The following is a description of a gene set: Human Gene Set: MIR5088_5P Genes predicted to be targets of miRBase v22 microRNA hsa-miR-5088-5p in miRDB v6.0 with MirTarget v4 prediction scores > 80 (high confidence targets). species: Homo sapiens from publication Chen Y, Wang X (PMID 31504780), and this is the list of marker genes: KDM2A, TMEM47, XRCC6, HIC2, GALNT2, THTPA, PTER, KCNMB2, PCDH10, AKAP3, ADCYAP1R1, SLC22A2, AGAP1, CANX, ZNF135, PI15 (NCBI Gene Id 51050), CENPI, RIMS4, IDS, BZW2, PRSS8, FGF9, PTBP2, PMP22, SH3PXD2A, LRRTM2 (NCBI Gene Id 26045), HECW2, USP14, PJA1, MSANTD2, MIP, CNTNAP2, CTDNEP1, VAPB, FUT10, ATPAF1, PSMB9, FOXO4, MECP2